The following is a description of a gene set: Human Gene Set: VERRECCHIA_DELAYED_RESPONSE_TO_TGFB1 ECM related genes up-regulated later than 30 min following addition of TGFB1 in dermal fibroblasts. Despite major advances in the understanding of the intimate mechanisms of transforming growth factor-beta (TGF-beta) signaling through the Smad pathway, little progress has been made in the identification of direct target genes. In this report, using cDNA microarrays, we have focussed our attention on the characterization of extracellular matrix-related genes rapidly induced by TGF-beta in human dermal fibroblasts and attempted to identify the ones whose up-regulation by TGF-beta is Smad-mediated. For a gene to qualify as a direct Smad target, we postulated that it had to meet the following criteria: (1) rapid (30 min) and significant (at least 2-fold) elevation of steady-state mRNA levels upon TGF-beta stimulation, (2) activation of the promoter by both exogenous TGF-beta and co-transfected Smad3 expression vector, (3) up-regulation of promoter activity by TGF-beta blocked by both dominant-negative Smad3 and inhibitory Smad7 expression vectors, and (4) promoter transactivation by TGF-beta not possible in Smad3(-/-) mouse embryo fibroblasts. Using this stringent approach, we have identified COL1A2, COL3A1, COL6A1, COL6A3, and tissue inhibitor of metalloproteases-1 as definite TGF-beta/Smad3 targets. Extrapolation of this approach to other extracellular matrix-related gene promoters also identified COL1A1 and COL5A2, but not COL6A2, as novel Smad targets. Together, these results represent a significant step toward the identification of novel, early-induced Smad-dependent TGF-beta target genes in fibroblasts. from publication Verrecchia F, Chu ML, Mauviel A (PMID 11279127) species: Homo sapiens, and this is the list of marker genes: DSP, FGD1, ITGA4, THBS1, EPHB2, LAMB1, NME4 (NCBI Gene Id 4833), EPHB4, WNT8B, CTNNB1, ARHGAP1, MMP17, MTA1, ITGA5 (NCBI Gene Id 3678), EFNA5, COL8A1, MMP2, NEO1, ITGB3, THBS2, IGFBP4, TNFRSF1A, SMO, MMP11, EPHA2, TNC, MMP1, RHOD, CTNNA1, COL16A1, PAK2, ILK, DVL3, SEMA3F, DDR1, ITGB8 (integrin subunit beta 8), RAC1